The following is a description of a gene set: Human Gene Set: GOMF_CHEMOKINE_BINDING species: Homo sapiens Binding to a chemokine. Chemokines are a family of small chemotactic cytokines; their name is derived from their ability to induce directed chemotaxis in nearby responsive cells. All chemokines possess a number of conserved cysteine residues involved in intramolecular disulfide bond formation. Some chemokines are considered pro-inflammatory and can be induced during an immune response to recruit cells of the immune system to a site of infection, while others are considered homeostatic and are involved in controlling the migration of cells during normal processes of tissue maintenance or development. Chemokines are found in all vertebrates, some viruses and some bacteria., and this is the list of marker genes: CCR8, ACKR1, FGF2, XCR1, CCR10, ITGAV, ACKR4, CXCR6, CCR3 (NCBI Gene Id 1232), PDPN, CXCR3, ITGB3, CXCR5, CX3CR1, CCR6 (NCBI Gene Id 1235), A2M, CCR4 (NCBI Gene Id 1233), CCR5, ITGB1, CCR1, ACKR3, HMGB1, CCR2, CXCR2, ITGA4, CCR7 (C-C motif chemokine receptor 7), CCRL2, ACKR2, CCR9, CXCR1, ZFP36, PLP2, CXCR4